The following is a description of a gene set: Genes predicted to be targets of miRBase v22 microRNA hsa-miR-4666a-3p in miRDB v6.0 with MirTarget v4 prediction scores > 80 (high confidence targets). from publication Chen Y, Wang X (PMID 31504780) studied in species Homo sapiens Human Gene Set: MIR4666A_3P, and this is the list of marker genes: RASGEF1A, UBE2H, VLDLR, SMG1, CEPT1, USP34, MRPS5, HIVEP2 (NCBI Gene Id 3097), CRISPLD1, IREB2, CHD1, STOX2, TRAF3IP1, PCDH19, ID1, ARMC8, ARIH1, GDPD1, RICTOR, MAP9, LRRC8B, SLC25A53, VPS29, TMOD3, TANC2, GPR158, UBN1, MRPL44, SYNGR3, AAK1, MECOM, LIN52, MTCL3, PPP6R3, CUL2, FBXO33, RAB11FIP2, BAZ1B, PNISR, FNDC3A, FA2H, TSHZ3, ARHGAP12, FOXO1, C4orf33, FGF7, DCAF7, FGF2, SFRP2, ZNF585A, SYVN1, WDR7, INPP4A (inositol polyphosphate-4-phosphatase type I A), THAP12 (THAP domain containing 12), ZDHHC21, MSRB3, AMMECR1, LSM14A, CMTM4, SERP1, WTAP, FZD3, PPM1L, ESF1, FLT3LG, BMAL1, YY1, BASP1, LIN9, BRF2, SMARCA5, SLC35A3, SENP7, CCDC126, BRDT, AP1S3, TARP, TEAD1, WWC1, CRIPTO, ZC3H11A, CREBRF, DNPEP, DOCK11, PTCH1 (patched 1), FBXO4, PAXBP1, MYCL, COG6, PDE5A, TMX4, ZC3H6 (NCBI Gene Id 376940), GUCY1A2, MAMDC2, LRRC4, CEMIP2, PALLD, ZNF160, LMO4, MON2, OSBPL9, LIPG, SOS2, FAM227A, PTAR1, MOB4 (MOB family member 4, phocein), TBL1XR1, CCDC186, ARID4B, NASP, SCN7A, HOXA9, DGKH, BTAF1, ADM, GABRG1, RHEB, TBCA (NCBI Gene Id 9549), KBTBD2, NRG1, ETS2, CCNG2, EDIL3, DMTF1, PHACTR4, OPA1, NT5C2, CEP44, MYCBP2, PSD3, PRDM12, SLC6A17, MGAT4A, EXOSC8, IFNW1, ASNSD1, GOLM2, CBFB, GP1BA, DCAF6, HMGXB4, ZNF521, PALS2, AHR, DNAAF10, DAGLA, SOX6, COG5, BPNT2, ATAD5, PPP1R2, HEATR5B, ZMYM2, MED14, CREBZF, USP25, VEZF1, BICC1, DCLK3, AKAP9, ULK1, AKAP12, CPSF6, PEX5L, LONRF2, CROT, ARPP19, MTRR, RILPL2, HMGCR, HHIP, TCF20, ITCH, UBE2W, PHIP, QKI, DENND4A, ABI1, ATP6V1H, SH3GL3, HS6ST2, MSTN, SAMD9, SPRED1, GRHL1, WDR35, CNTN5, FBXO38, ARHGAP44, EPHA7, MEF2C, CAMTA1, EIF2B3, KCNJ15, CFAP43, SGIP1, PI4K2B, MTPN, HSF2 (NCBI Gene Id 3298), TAOK1, MBNL1, UTRN, ATRX, NGDN, PPM1K, FRMD4B, ID4, EIF4A2, PLN, KCNC2, ERAP1, F3, ATP6V0A4, ZNF236, IRX3, ARRDC3, SLC6A14, TAOK3, LMLN, ASB11, FBXO43, WDR37, TCEAL9, PSIP1, TMEM132B, PTBP3, ZNF652, CADM1, SGK1, HDAC9, SLIT2, KRR1, GPC6 (NCBI Gene Id 10082), SOX9, ADRB2, NBEA, GTF2A1, TMEM196, SLC2A13, FNDC3B, PPP3CA, ACVR2B, PDCD6IP, SLC38A2, MARCHF6, HDAC4, ZNF800, NUFIP2, ABCC5, ASAP2, NF1, WIPI1, PCNP, CNOT6, PPP2R5C, NR5A2, WDR3, OSGIN2, KLF6, BTF3L4, DRD1, ZC3H12B, SCN2A, EBF3, GOLPH3, NEUROG2, RAB3GAP2, KLF10 (NCBI Gene Id 7071), LATS1, CCNY, TGFBR1, KDM6A, ITGB6, PLAG1, HEATR5A, FYTTD1, MKLN1, CD38, PTPRE, STRIP2, DACH1, ARID5B, RRM2, NEDD9, PCDH8, HSPE1-MOB4, AGR2, NUDT4, IRS1, ACTR3, GABRB3, PAQR3, NDC1, ZNF85, KRAS, PTPDC1, PIKFYVE, PABPC1L2B, SPTB, DOCK1, TAF13, ROCK1 (Rho associated coiled-coil containing protein kinase 1), SCAMP1, TNS3, SRSF1, ADH5, TMEM170B, RAB28, PREX2, FOXJ3, PPP6C, DYNC2LI1, TRIM71, TUT4, KL, PPP1R21, MSANTD2 (NCBI Gene Id 79684), PUM2, TRIM63, CHIC1, TMEM87A, CILK1, CDH20 (NCBI Gene Id 28316), RFK, FSTL5, RDX, EMP2, TERF1, KCNG3, GDAP2, KLF5, FOXA1, RAP2C, ZFAND5, DOP1A, BDNF, OXR1, PSD2, C2orf66, LRP2, MFSD14A, DMXL2, CSTA, KRBOX4, GSK3B, ACSL3, BICD2, GPR37, STRN, TLE4 (TLE family member 4, transcriptional corepressor), LYSMD3, BCL11A, ZNF615, TOB1, GRM3, ETNK1, GTF3C4, MBD2, DMXL1, WBP4, CSMD1, ZNF273, SOAT1, RABGGTB, NPY, RAB10, COL19A1, DDX60 (NCBI Gene Id 55601), RABGAP1, KLF4, SYT1, HOOK3, NAALADL2, KMT2C, SELENOK, SLC12A8, MALT1, ITM2B, SORBS1, RAB2A, ZBTB44, VAPA, TCF3, SMURF2, TTC6, FOXR2, FANCM, DCUN1D4, TMEM39A (NCBI Gene Id 55254), SOCS6, ZNF426, FBXO34, DCLK1 (doublecortin like kinase 1), E2F5, PNPLA4, NLGN1 (NCBI Gene Id 22871), ANKRD49, AKT3, IL23A, PPM1A, FREM2, KPNA4, VPS13B, MNX1, ESRRG, CASD1, CYFIP1, LRP6, MARK1, LCORL (NCBI Gene Id 254251), CRIM1, PID1, EEA1, ZBTB18, SH3GLB1, MCL1, SNAPC1, ZFPM2, RNF138, GBP5, PAN3, TMTC3, CHSY3, TRAK1, SCAI (NCBI Gene Id 286205), PIK3R4, BMS1, KCNJ3, HOXC8, EREG, SMARCE1, HTR2A, PIK3C3, RFX7, KLF2, SGO1, RNF115, PRDM2, RAP1A, TBRG1, PDCD2, CREB3L1, FERMT2, SEPTIN9, GRHL3, SBNO1, ITGAV, LRRC1, NR3C1, USF3, CCNA2, MACIR, PRPF8, CLIP1, MMS22L, MAST4, CEP76, TMEM161B, RAD21, SLC5A7, ARAP2, DDX59, OLFML2B, ST8SIA4, BMPR2, HEMGN, C10orf88, TM4SF1, FNIP1, SLC4A5, SORCS3, BRD1, ZFY, B3GNT2, HECTD2, SLC18A2, BMPR1B, ZBTB14, HSPA13, LRRCC1, ITGA6, WDR72, NAA16, SLC4A4, FAN1, CLOCK, TRGC1, YIPF4, RIMKLB, AHDC1, RASEF, HERC2, CDK19, MYSM1, NFYB, SPOCK3 (NCBI Gene Id 50859), MCTP2, KIF3A, CNOT6L, KIAA0408, APLF, CDS1 (NCBI Gene Id 1040), BNC2, IL6, PPP2CA, ZNF260 (zinc finger protein 260), LRRC7, POLR2K, PURA, PPP1R15B, GTF3C3, LRPPRC, NKTR, ZC3H12C (NCBI Gene Id 85463), GNAQ, ANK3, KDM7A, NAA15, TRPM7, STXBP5L, PPP1R12A, FUT9, UBFD1, NCOA2, TMTC4, ZNF597, FRS2, MYO1E, ZC3H4, MAP4K3, PLEKHH1, PAFAH1B1, CA2, NEK7, ZFX, CBLN4, NAA25, PDLIM5, MBD5, USP12, HOMER1, RFX1, JAG1, PLPP6, HIVEP1, RALGAPB, ZNF136, YTHDC1